The following is a description of a gene set: studied in species Mus musculus The t(14;18)(q32;q21), resulting in deregulated expression of B-cell-leukemia/lymphoma-2 (Bcl-2), represents the genetic hallmark in human follicular lymphomas. Substantial evidence supports the hypothesis that the t(14;18) and Bcl-2 overexpression are necessary but not solely responsible for neoplastic transformation and require cooperating genetic derangements for neoplastic transformation to occur. To investigate genes that cooperate with Bcl-2 to influence cellular signaling pathways important for neoplastic transformation, we used oligonucleotide microarrays to determine differential gene expression patterns in CD19+ B cells isolated from Emu-Bcl-2 transgenic mice and wild-type littermate control mice. Fifty-seven genes were induced and genes were repressed by > or =2-fold in Emu-Bcl-2 transgenic mice (P < 0.05). The suppressor of cytokine signaling-3 (SOCS3) gene was found to be overexpressed 5-fold in B cells from Emu-Bcl-2 transgenic mice. Overexpression of Bcl-2 in both mouse embryo fibroblast-1 and hematopoietic cell lines resulted in induction of SOCS3 protein, suggesting a Bcl-2-associated mechanism underlying SOCS3 induction. Immunohistochemistry with SOCS3 antisera on tissue from a cohort of patients with de novo follicular lymphoma revealed marked overexpression of SOCS3 protein that, within the follicular center cell region, was limited to neoplastic follicular lymphoma cells and colocalized with Bcl-2 expression in 9 of 12 de novo follicular lymphoma cases examined. In contrast, SOCS3 protein expression was not detected in the follicular center cell region of benign hyperplastic tonsil tissue. These data suggest that Bcl-2 overexpression leads to the induction of activated signal transducer and activator of transcription 3 (STAT3) and to the induction of SOCS3, which may contribute to the pathogenesis of follicular lymphoma. Genes down-regulated in primary B lymphocytes engineered to overexpress BCL2. Human Gene Set: VANASSE_BCL2_TARGETS_DN from publication Vanasse GJ, Winn RK, Rodov S, Zieske AW, Li JT, Tupper JC, Tang J, Raines EW, Peters MA, Yeung KY, Harlan JM (PMID 15561778), and this is the list of marker genes: BID, CFP, MYL4, NFKBID, HCST, MFHAS1, MYB, ANXA4, DPH5, CMTM3 (CKLF like MARVEL transmembrane domain containing 3), FN1, EDARADD, BCL2, ELL3, ACKR2, SPMIP4, PTPN22, PGLYRP1, MCOLN3, F13A1, MPHOSPH9, MAP4K4, TERB1, TRMT10A, MPO, TCF7, CR2, DENND2D, LIG3, NEDD4, PLXNC1, MMUT, CD9, PLA2G7, CMTR1, PIK3R4, TMEM25, CTSG, ACKR3, C19orf12, RTEL1, ABCC1, CYFIP1 (NCBI Gene Id 23191), IFI16, MARCKS, TUBG2, STMP1, TRPS1, TRAF1, LYZ, KIF20A, CCR1, COL5A1, RASGEF1B, HERC6, LTA, CD1D, CCND2, CARMIL1